The following is a description of a gene set: Reactome Pathway: Defective cleavage of FV variant at a.a.534 part of: Defective FV causes thrombophilia  species: Homo sapiens Factor V Leiden (the most common) and Factor V Bonn thrombophilias are inherited conditions caused by the missense variants FV R534Q and FV A540V, respectively. These genetic mutations lead to resistance to activated protein C (APC), impairing its ability to inactivate factor Va (FVa) by cleaving it at residue R534 (Bertina RM et al., 1994; van Stralen KJ et al., 2008; Pezeshkpoor B et al., 2016). The defective cleavage of these FV variants may also interfere with APC-mediated inactivation of factor VIIIa (FVIIIa), where non-activated but APC-cleaved FV functions as an APC cofactor (Váradi K et al., 1996; Pezeshkpoor B et al., 2016). In addition to APC resistance, FVa Bonn (A540V) exhibits increased affinity for factor Xa (FXa) (Pezeshkpoor B et al., 2016), which diminishes APC-mediated cleavage at R534, as FXa and APC share a common exosite on FV. These conditions result in prolonged FVa activity, enhanced function of the prothrombinase FVa:FXa complex, and sustained thrombin generation, which may increase the risk of developing deep venous thrombosis in individuals carrying the FV Leiden or FV Bonn mutation., and this is the list of marker genes: PROS1, PROC, F5